The following is a description of a gene set: Genes containing one or more binding sites for (ZNF592) in their promoter regions (TSS -1000,+100 bp) as identified by GTRD version 20.06 ChIP-seq harmonization. Human Gene Set: ZNF592_TARGET_GENES from publication Yevshin I, Sharipov R, Kolmykov S, Kondrakhin Y, Kolpakov F (PMID 30445619) studied in species Homo sapiens, and this is the list of marker genes: CCDC144A, PTP4A2, MRPL22, COPS6, LNMICC, SSC4D, LARP1, E2F5-DT, COL6A4P1, BCL7C, LAMTOR1, OPN3, DBP, PDIA5, COASY, BRME1, WRAP53, EPHX2, ZFX-AS1, TMEM131L, GOLGA5, CDIP1, LEMD3, TMEM144, DHRS13, TMEM165 (transmembrane protein 165), ZNF609, PMM2, ADD2, DFFA, MGAT1, SPINT2, LTO1, NEK11, JADE1, PER3, ABHD14A-ACY1, PHF20, HDGF (NCBI Gene Id 92300), NADK, CASC3, HMGXB3, TRGV6, UQCC1, KIF2A, MACROH2A1, ZSCAN31, LINC02901 (long intergenic non-protein coding RNA 2901), CLTB, GPR107, MLPH, WARS2, WDR89, ABCC5-AS1, PSMB6, TRIM8 (tripartite motif containing 8), TLE3, UQCRH, NELFE, FABP5P3, ABCC3, ENSG00000265055, AGPAT3, LHPP, JOSD1, SUCLA2, HMCES, LINC00674, SRXN1, SNHG4, PRR3P1 (NCBI Gene Id 101060648), PKN1 (protein kinase N1), WASF2, SPDYC, TXNRD1, PABPC4, ADCK2, PRAF2, MGA (NCBI Gene Id 84130), AHCYL2, EML3, SMIM10, MRPS21, MEX3C, TRIM8-DT, SLC2A1-DT, THUMPD3, MIR4659B, STARD9, CRYBG2, ATG13, RNU5B-1, SP2-AS1, CHML, C2orf49, IRX2, MYBBP1A, MCRS1, MAPRE1, TNFRSF10C, IL10RA, PRKAR1B, ODC1, RNF166, TSSK3, LEPROTL1, EZR, TRG-AS1, CLDN4, RPSAP31, ZDHHC8BP (NCBI Gene Id 150244), RAD9B, IMMP2L, FZD6, NKX3-2, HIPK2, CYB561D2, EVA1C, SMARCD2, CDK20, KANSL3, HMGA1, ZNF566-AS1, RNF149, RAMAC, RNU5F-1, POLR3E, SCMH1-DT, PFKFB3, NOTUM, MIR451B, RRP1B, SCAPER, CALCOCO1, ZNF341, FAM78A, FBXL19-AS1, DGCR8, TRNAU1AP, RNVU1-32, CHP1, AMOTL2, PDS5A (PDS5 cohesin associated factor A), HOXB3 (homeobox B3), TEX22, SHLD3, PUF60, LINC02863, RC3H2, C2CD2, ATP2B1, SNX27, TTC13, ATP5MC1P3, ZNF385A (zinc finger protein 385A), OPLAH, USP10, POLR3A, XYLB, INSR, NUMBL, HNRNPL, RAB7A, ERP44, CARINH, CAV1, RBM8A, CHST1, NUMA1, AKR1A1, ASB8, AMN1, ARHGEF10, MAJIN, RNVU1-2A, PVT1, HES1, ARFGEF2, POM121C, MIR3939, CAST, TNFRSF1B, STAR (NCBI Gene Id 6770), FAM98B, TCTN1, LRFN4, HCFC1, UBE2F, METTL13, KLF10, MRPL20, IGF1R, NAGLU, ISLR2, CISD3, ZNF644, SMPD3, DCTPP1, IGDCC4, MELTF-AS1, GAS8, LINC03108, CHD2, PSME2P3, CILP2, NDC1, LINC01610, PUDPP2, R3HDM2-DT, AP1G1, MDH1, SUPV3L1, NUFIP2, TBXAS1, SH2D6, SLC7A6OS, ENGASE, LIX1L-AS1, RNU7-27P, HMOX2, METTL23, IDH3B-DT, DEK, COL4A2, BCL7B, RPS6KA3, LINC01623, GFY, PROCA1, CCDC136, DDX19B, MECR, MPDU1, MID1IP1, CTSH, MFSD3, VTRNA1-3, RGCC, ELOVL1 (NCBI Gene Id 96722), TRMO, MRPL52 (NCBI Gene Id 122704), IL5, WT1-AS, GCLM, REX1BD, MXD1, FLNB, SEMA3B, HLTF, COQ8A, ACTR3C, ANO10, TTLL4, ANXA11, AVPI1, TRIM7-AS2, SMIM12, APMAP, NDUFA10, ST3GAL5, NR6A1, MITF, RNF130, YBX1, CAP1, SPHK1, MPHOSPH6, CBX7, CHMP4B, ARL16, MOB3A, FADS1, PRELID3A, CARD8, ZNF48, MSL3, MADD, CRAT, REV1, DMAC2L, YPEL3-DT, FEM1A (fem-1 homolog A), PYCR2, ADI1, IP6K1, UPF1, TOLLIP, MED16, PEMT, MRPS6, ENSG00000239137, GFUS, UGGT1, SNAI1, TMEM241, GRK6, WTAP, HJV, FHL2, UCKL1, ZNF282, SEC24C, SNF8, BAG6, KLHL21, ANGPTL6, ZCCHC7 (zinc finger CCHC-type containing 7), ZFYVE28, MFSD4B, GPR176-DT, TSNAXIP1, SYF2, RHBDD1, ATP5F1A, ALKBH2, KNL1, LETMD1, PEDS1, ZNF8-ERVK3-1, DDX50, CCS, KLF13, PSMB4, ZFP91-CNTF, NDUFAF5, SLC25A6, VSIG10L-AS1, ROM1, ACCS, EPDR1, KCNH1-IT1, PACSIN3, MYO1D, DENND6B, TRMT12, RNPC3, GLS2, RABGGTA, RAB29, HM13-IT1, MAPK6-DT, DLGAP4-AS1, SPAG4, DIAPH1, ENSG00000212144, DHRSX, PPP4R1, PTP4A1 (NCBI Gene Id 7803), LINC01732, PPP1R3D, TELO2, ARF4, BAGE2, CSTF3-DT, PUM1, MAP1LC3B (NCBI Gene Id 81631), TMC8, BEND6, TYSND1, PITX1-AS1, SLC7A5P2, WIZ, CLPX, C12orf76, CHCHD10, CCDC59, MEPCE, TCP10L2, GMEB1, APOO, ZMAT1, POLE2, LIMD1, RHBDD3, PTRH2, STK17A, OLMALINC, SBF2-AS1, RPL10, STAU2, IWS1, RNU2-2P, CDCA4, USP49, ELOVL2-AS1, ENSG00000260830, TADA2A, RP9P, GPCPD1, TFEB, DNAJC11, RFX2, CTSF, CCDC8, TXLNA, TOMM20, SNAPC4, DYNLT4, DPP3-DT, PRPF40B, HISLA, CTTN, ABHD14B, RASGRF1, GNG4, LDHA, KRT7, OXA1L, STC2, HDHD5-AS1, DNAAF5, TAF2, BTRC, DSCR9, POLR2I, C1orf159, ZNRF2, GAB2, KRIT1, STN1, CCDC106, ST3GAL5-AS1, FBXL5, SCARB2 (NCBI Gene Id 950, scavenger receptor class B member 2), ITGA3, CHD7, NCOA6, RRP1, GIT1 (NCBI Gene Id 28964), C19orf38, TMEM186, VPS36, VPS29, SPG11, GNPTAB, MIR4727, SETD2, PHACTR1, NMT1, RYK, TONSL, FOXRED2, CTDSP1, EMD, C2orf42, SRRM2, VPS9D1, CPSF1, KCNAB1, NCOA5, SRGAP2, PROCR, ENSG00000279561, CENATAC, NFIB, FABP5, TEX19, R3HCC1, DST, CXCL3, NPL, LINC01770, CYP2R1, ADAR, FNIP2, HIKESHI, BFAR, GLOD5, LACTB2, LINC02709, ZMIZ2, TTC41P, EXO5, ZKSCAN2, KHNYN (NCBI Gene Id 23351), DPP9, PLPBP, AAAS, TOB1, PRDX3, ULK3, CAB39, RAB8A, ARF6, ZNF280C, GOPC (NCBI Gene Id 57120), TULP3, CDC16, SFT2D3, DOK7, NEPRO, SMG1P3, TMCO3 (transmembrane and coiled-coil domains 3), MAP7, TRAPPC8, SNHG20, SETDB2, ATIC, ACTR3-AS1, GABPA, SORBS1, TMC6, SUSD3, MTHFD1, SLC38A1, WDR26, GGA2, ENDOD1, TMEM40, EBLN3P, PICK1, ASTE1, TNFRSF8, TRIM33, ACSL3, HS1BP3, RPS26, LHX6, FADS2, TOB1-AS1, SMC3, ARL4A, TK2, SEC61A2, PLEKHJ1, CCDC122, SLCO4A1, ZNF598, HNRNPH1, HLF, MARVELD1, TMEM14B, TRIM59, UTP14A, TPRA1, ZNF250, PDE12, EBNA1BP2, PRKAB2, PPP1CA, PCNX4, STXBP5-AS1, JPT2, NEK3 (NIMA related kinase 3), SLC12A2, TEX14, TMED1, PEAK1, STAU1, PARK7, CAND1, RPS11, PUM2, OPA1, TMEM11-DT, PIGL, TIMM50, PDCD6IPP2, NOC4L, TUBB2A, MCCC2 (NCBI Gene Id 64087), HFE, BCL9L, PARVB, ACER3, PAXIP1, SLC9A3-OT1, CSNK1G1, KATNA1, LARP1B, ZNF497-AS1, SKAP1, PTCD1, PEX14, EOLA2, SUDS3, KDM3B, NXT1 (nuclear transport factor 2 like export factor 1), GPR176, NDST2, ATP5F1B, FARSA, OXA1L-DT, DGAT2, PHF19, SNORD49B, FBXO34-AS1, HTATIP2, VPS37D, EIF3B, TGIF2, NOS3, RNU6-1, ATMIN, PRANCR, WWP2, CCDC88B, BPTF (bromodomain PHD finger transcription factor), CSRP1-AS1, TMEM183A, GNAS, RIOX2, ACSF3, EIF2B5, RNF213, C2orf92, ZNF580, CNOT6, ADSS2, ZNF707 (zinc finger protein 707), LIG1, FAM157A, REXO1, FAM24B, ENSG00000255326, VCPIP1, VDAC2, TMEM201, GPR180, LINC03072, TNXA, TULP2, CARM1, ICAM1, PPT1, SLC25A45, BUB1B, CNOT9, HACD3, SAXO5, SETD4, GCFC2, EBAG9, ZFYVE1 (zinc finger FYVE-type containing 1), ACBD5, ARHGAP22, RAD9A, LDLRAD4, TGFBR3, ARHGAP25, NARF, PHLPP2 (NCBI Gene Id 23035), DEF8, SMARCC2, CCDC137 (coiled-coil domain containing 137), GPR3, LINC01932, RENBP, FRMD8, PXN (paxillin), ZFPM2, FAM76A, TCERG1, DNAAF4, RNU6-194P, MTMR10, PROKR1, ADNP, BCKDK, SAMSN1-AS1, GCN1, EGFLAM-AS4, FBXO31, PRKAR1B-AS1, ITGAE, SEC24B, ALG5, EEIG2, LINC01089, NAPSA, THEM6, AKAP10, PPP4R1-AS1, SMURF2, PYGM, YPEL3, MTMR9LP, F11-AS1, SLC35F6, PDE4A, BTBD19, FOXK1, LRRC56, SPTSSB, PCBP1-AS1, HMGN1P37, ZSWIM9, LINC02985, XPO7, CYTH3, CATSPERG, PLEKHG2, RNA5SP236, KLF6, RPTOR, HMGB1, IFRD2, UBE2V2, ODR4, MATR3, ELOVL2, SEH1L (SEH1 like nucleoporin), MYO3B-AS1, EPM2A-DT, NBPF11, CTCFL, METTL2B, NYAP1, GCLC, DNAJC12, KHSRP, LINC02159 (long intergenic non-protein coding RNA 2159), LTBR, SP1, SYNGR3 (NCBI Gene Id 9143), C15orf61, ALDH3B1, HMMR, NFIA-AS1, DEGS1, VPS26C, CDRT15P3, RFFL, ANP32B, PBX3, DPP3, GREB1, ZNF248, SCAND3, ZNF408, IMPDH2 (NCBI Gene Id 3615), RPL37, MIR4530, PDS5B, TH2LCRR, PLEKHG4, RANBP2, CLCN7, FAM138E, SLC6A6, NUP98, SDF4, TDP2, ERI1, LNX1, MELTF, TARS1, RAE1, VPS26B, FKBP5, VPS16, HMX3, ANKRD13A, IFTAP, KIFC1, VTI1B, ERP29, SNORD25, CFB, HELZ, SCML2, DCAKD, ESYT2, RAD51C, LINC01702, MIR4470, XKR9, DNAH10, ZNF747, ENSG00000263280, ZNF77, HOXB-AS3, SUMO2, TMEM258, FAM50A, G6PD, B3GAT3, SYT12, B9D2, HSPG2, NAPEPLD, HEIH, EIF3L, TRMT10B, N6AMT1, DLGAP4, TMEM184A, FBXO34, SFT2D2, CISD2, OSBPL8, MGME1, PSMC5, MIS18BP1, VILL, MCRIP2, PAXIP1-DT, MYO18A, SIAH1, CHASERR, HMBS, EOLA1, LMCD1-AS1, ASPH, YTHDF1, NFE2L3, ZNF155, HADHA, STOML1, NRF1, CCDC83, ABCA17P, F2RL2, RHOH, LINC02354, LIMD1-AS1, KMT5B, ICE1, CHID1, ZNF226, RLIM, ACSM3, ZFAND5, HM13-AS1, GTF2IRD1, ZGPAT, BRF1 (NCBI Gene Id 90137), EGLN2, CAPN7, MMP24OS, USP37, PLCB2, TMX4-AS1, RILP, HCG20, PPFIA4, POLR3G, DLG5-AS1, NADK2, AGPAT5, ABHD17B, AP2S1, EMC1, IL13RA1, PLK3, PER1, ATP7B, KSR2, LINC02777, FAM217B, MMP11, GTF3A, ATP2B4, TOM1L2, DNLZ, DDX23, ZKSCAN2-DT, WDR83, ANKRD36B, GFM1, FOXK2, WDSUB1, MDN1, NEU4, CYC1, ZNF566, RNY3, BCAP29, HARS1, PIP4K2A, HMG20A, HARS2, DNM2, RCE1, RNU6-9, TRA2B, PPAN-P2RY11, STXBP2, SPOPL-DT, ZNF581, LINC02952, POU6F1, PINK1, CAPNS1, TRAP1, SUPT16H, CFAP97, ANKRD53, USP32, ATG12, DRAP1, ZNF775, KLF11, L3HYPDH, EME1, PANK4, ANKLE2, B3GNT4, ASAP3, ETV2, WIPF2, ATP5MF-PTCD1, CLPB, NTPCR, SNHG29, DDX11L10, NSUN5, IMPA2, KLRG2, NBPF12, SUPT5H, AHCTF1, ARHGEF6, ALDOA, RDH13, MIR4706, RGS10, MMP25-AS1, PECAM1, EXD1, FICD, NUDT13, METTL5, ATP9B, LCA5L, RANBP10, MAPRE2, RSAD1, SHF, MAX, NFE2L1, KLHDC10, GNA13, CFAP418, ZNF646, PIWIL4, ARL5AP5, DUSP14, SNX5, CRK, PRKACA, PIM3, RAB6A, HNRNPA0, IL34, LINC01424, GHET1 (gastric carcinoma proliferation enhancing transcript 1), MTERF3, WT1, DNAAF4-CCPG1, UBAC1, MAPKAPK5-AS1, ENSG00000255428, HACD2, ADK, DNAJA3, SHROOM1, HNRNPU, RBM4, DNAJA2-DT, OCIAD1, MYH9, GOSR2, RNY4, CCDC85C, ST3GAL2, MEST, ZNF280D, F2RL3, CSRP1, STK19B, SLC2A4, TCEA2 (NCBI Gene Id 6919), SERPINE1 (NCBI Gene Id 5054), HCG14, P2RX2, PRECSIT (p53 regulated carcinoma associated Stat3 activating long intergenic non-protein coding transcript), LRSAM1, RAPGEF1, CEP350, ARFRP1, COCH, VTRNA1-2, INTS1, WRNIP1, PPP1R12C, PAICS, MINCR, RWDD3, LINC01629, PPP1R14B, TANGO6, MIR153-1, RWDD3-DT, EZH1, DYNC1LI2, EEA1, BOD1, WDPCP, MCRIP1, LSM14A, POLG-DT, NCAPD3, ALG1L13P, SBNO2, PUS1-AS1, TEX30, SNRNP70, ATP2A3, GRN, ZNF341-AS1, FBXO38-DT, CTSD, CHD9, SF3A2, LINC00689 (NCBI Gene Id 154822), PCNX4-DT, SH3GL1, ANKRD54, RALGDS (ral guanine nucleotide dissociation stimulator), KDM3A, TEDC1, MSL3-DT, STKLD1 (serine/threonine kinase like domain containing 1), DYM, PIEZO1, PNPT1, CIC, INVS, CERS6, RAB4A-AS1, HSP90AA1, MAPK8IP3, TRIM39, SKIDA1, EWSR1 (NCBI Gene Id 2130), IFITM2, MIRLET7IHG, GLS, GTF3C4, ZBTB8OS, TRPV2, MTHFR, ACACA, TPR, PPM1A, RNF223, TOMM34, PDF, BTNL9 (butyrophilin like 9), IFI27, UBE2G2 (ubiquitin conjugating enzyme E2 G2), MMRN2, MIR6508, WBP1L, RPL13, PTPRS, TSNARE1, NRDE2 (NRDE-2, necessary for RNA interference, domain containing), RADIL, TFAP2A, ARHGDIA, CREM, DHX40, PPP1R3F, FAAP20, DUSP28, ZNF460, PLXDC1, CCDC174, MYLK-AS1, NCOA3, FPGS, KCNN4 (NCBI Gene Id 3783), ZNF444, DIABLO, LNCATV, MFSD4B-DT, VSIG10L, C17orf99, NDUFS3, IL1R1, HMGB3P22, SRSF1, GALNT7-DT, PAFAH1B1, SRRM3, ENSG00000266401, BMP1, DIAPH1-AS1, CAPG, CXCL11, RBBP8NL, NME1 (NME/NM23 nucleoside diphosphate kinase 1), RAD54B, PXK, SEL1L, MIR5684, PKNOX1, MIDN, ABCF3, CACTIN, SACM1L, EMG1, RIOX1, CISD1, SLC4A2, SEC16B, CCDC57, STX3, SCRIB, KIAA2013, MRPL53, PTPA (protein phosphatase 2 phosphatase activator), CTBP1-DT, EIF1P2, MIR4766, RHOF, SNORD54, JKAMP, VPS4A, DHX8, ENSG00000227355, NR2F2, CNIH3, IKBKB-DT, HERC1, INF2, SYPL1, PPAT, TRAF4, UTP11, OXSR1, ESD, SNX9 (NCBI Gene Id 51429), METTL26, TRAPPC13, VMP1, STAT6, CCDC183, FBXW5, FEN1, PIR, ZNF496, TPM4, TMEM11, KRT7-AS, RIN3, MORC2, ATF7IP2, SLC7A7, CTNNBL1, SLC5A3 (NCBI Gene Id 6526), COMTD1, RPS20 (NCBI Gene Id 6224), RHOBTB1, AGPS, ADSS1, PNPLA6, VDR, ELOVL5, KAT5, SLC7A8, CARD8-AS1, CCDC125, SNHG7, KSR1, FBXO38, EXD3, COPS7A, RELT, PTMA, PUS1, RNVU1-15, TNIP2, BMP8B, DYNC1LI2-DT, UBXN11, RNF138, ZNF398, FN3K, ATP8B1-AS1, LINC01547, TRIM45, GGACT, MRTO4, EHF, DHX58, SPOPL, IDH2 (isocitrate dehydrogenase (NADP(+)) 2), MRPL43, GRK4, DDX3ILA1, R3HDM2, REEP3, ESF1, FBXL18, MVK, TCFL5, LRRC3-DT, TMEM248, DDX11L2, ZNF584, TRIM47, NORAD, TMEM80, PPP4R1L, AKAP11, LINC02695, RAB11A, UBE2F-SCLY, SYT8, MGC4859, USP14, DEPDC7 (DEP domain containing 7), TMEM44, CEP131, CFAP418-AS1, CP, PGD, SEMA3C, ANKRD52, TASOR, SLC12A2-DT, UFSP1, IDH3B, RPL36P8, ZNF32, MTREX (NCBI Gene Id 23517), PLLP, KLK12, NRARP, MIR193A, RBBP4, UCP2, CASP7, CKLF, RNH1, SLC7A5P1, OTUD4, NETO2, EIF4ENIF1, SNHG1, KIAA1958, KLHL17, RERE, NEK8, DNAJA1, FIRRE, MIER2, PPP4R2, ZFYVE27, FAM174C, NKD2, CDK5RAP3, CYB561, SIRT7, E2F6P4, ODAD3, RHOG, ZNF668, RNPC3-DT, RYBP, UBTD1, POLR1A, EML4, WDR74, KMT2C (NCBI Gene Id 80260), MALAT1, LINC02252, IKZF3, IRF2BP2, MAP2K2, WEE1, APPL2, NGLY1, L2HGDH, CBLN3, ZMYND8, MIR4492, CFLAR-AS1, TMEM187, DEDD, CNOT2, CENPN-AS1, SEPHS2, LSM10, GTF3C3, GATAD2A, ING4, DHDDS, NOC3L, HMBOX1, MAZ, AGO3, CACNA2D4, RPS13, TSSC4, DNAJA2, KRR1, CASTOR2, SMAD2, EVI5, HNRNPF, AFF4, RPL12, CST9, FBXO30, ARV1, FCGR3A, GASAL1, TARBP2, EHD1 (EH domain containing 1), SLCO2B1, WARS2-AS1, TBX10, SCAMP5, CHCHD1, RN7SKP119, ZNF513, ZMYM4, SNORD26, NT5C, RBM17, DNA2, REXO2, ENSG00000206898, LINC02577, RNU6-1160P, SEPTIN9, ZFAND4, STUB1, MIR3181 (NCBI Gene Id 100422972), EIF2D, ZSCAN5A-AS1, CAPZA2, ARRDC4, DUS1L, GNL3L, RCC2, PPFIA3, CYLD, ARHGAP1, RBM26, NR0B2, N4BP2, ZNF248-AS1, SDHC, WDR76 (WD repeat domain 76), SRGAP3, NECTIN2, CALM2, RRP36, MEIOB, RNU1-108P, SYT17, TBCD, CDK5, TNFAIP8L1 (NCBI Gene Id 126282), C5AR2 (NCBI Gene Id 55868), ARHGEF5, KCTD5, POLD1, ZFP91, GIRGL, STK25, LZTR1, TUBGCP3, ATG16L2, VPS13D, HCG18, UBTF, MAP4K4, H4C3, DNMT3B, UBA5 (NCBI Gene Id 79876), BAIAP2L1, CERNA3 (NCBI Gene Id 105375847), DNALI1, KIAA0232, TRIB3, FNBP4, PITX1, CSTF3, DERL2, RHOT2, CANT1, ASPSCR1, SAMD9L, CIRBP, PLSCR1, SART3, PDHB, SGPL1, PGBD2, ZNF746, SRSF4, AEBP2 (AE binding protein 2), ODC1-DT (ODC1 divergent transcript), TSPAN14, SMPD2, DPP7, H2AZ2P1, DGUOK, ZMYND15, RNF38, CCAR1, METTL25, VAC14, FAM234A, ELOVL3, USP11, MC1R, LINC00963, HSDL2-AS1, ATP5PF, DEF6, AP3S1, TSPO, VARS1, ADRM1, CTBP1, ZNF510, SLC26A4, ATP2A2, CPNE2, RHCE, SBNO1, PRDM15, CCND1, WNT10A, VWA1, MFAP3L, RPL36AP19, LINC01641, PCBP4, CNTD1, RNU6-1219P (NCBI Gene Id 106480649), COA3, INTS9, MACC1, MIR5696 (microRNA 5696), RASIP1, TRIM59-IFT80, ZNF131, TOMM40, MIR6070, DLG5 (discs large MAGUK scaffold protein 5), RNY1, SLC43A3, PRKCQ-AS1, TNFRSF10A-DT, CCDC88C, LSM11, VPS37B, IBA57-DT, IRX3, TMEM268, PRCC, SRGAP1, SNORD68, KIF9-AS1, SLC34A1, TCF25, PRMT7, PPFIA1, DOCK1, ATP5MF, STRIP1, SSBP4 (single stranded DNA binding protein 4), FAM32A, TP53, FTSJ3, PHF8, FBXL19, UBXN8, LINC03016, CXCL16, UPF2, NANP, PEDS1-UBE2V1, SRP19, MIA2, SGTA, TMED3, LTBP4 (latent transforming growth factor beta binding protein 4), SLX9, KBTBD6, NIBAN2, RSRC2, RPL7P41, TRIP6, NSD3, DR1, KCNH1, SKA1 (NCBI Gene Id 220134), DEAF1, SLC29A1, ATP5MC2, GYPA, C10orf95-AS1, RIOK2, IBA57, RSRP1, GPR160, SH3TC1, IL4I1, HADHB, CEP68, KLHL20, TKT, ITGB4, CCDC120, CDH1 (NCBI Gene Id 999), GSTP1, NME6, MCL1, PCNX1, IFI16, HEXIM1, VCF1, C6orf62, DLD, CDK5RAP2, ACADM, RMI2, ZNF384, S100Z, LAMB3, SERPINB6, PNMT, FANCL, SYCP2, PMS2, CUL4B, ENSG00000233017 (NCBI Gene Id 105372710), MIR4526, PCCB, PSD4, SLC7A5, NDUFA13, CFAP99, NUDCD2, ABCA3 (NCBI Gene Id 21), KLC1, CCDC6, C10orf88, IQCH-AS1, WDR83OS (WD repeat domain 83 opposite strand), LACC1, CKLF-CMTM1, PPM1L, PPAN, TMEM116 (NCBI Gene Id 92920), SRSF5, ANTKMT, LRRC8D, MIR4736 (NCBI Gene Id 100616220), CFLAR, LUC7L, CENPA, CTU2, SLC3A2, NFIA, NAA80, TBC1D31, MALSU1, PLXND1, FXYD5, SNX25, ICAM2, ORAI1, SCARB1, ZC3H7A, TEAD3, ATF5, LGALS8, CHCHD2P2, PBX3-DT, PCBD2, GTF2F2, SSR3, H3-3B, PCAT14, UCP3, SLC19A1, BICD2, NOP14, ZNF276, LINC02934, VMA21, LASP1, SURF6, ZNRF1, RAB3IL1, POLE4, POGK, TTC39A, OXSM, IL6, C11orf58, DHX29, NUP62, SYT5, PDE3B (phosphodiesterase 3B), KCTD10, BAALC-AS1, CELF1, AGL, FAM174B, ITFG1-AS1, ZNF12, TCAM1P, ZFX (NCBI Gene Id 7543), CMTM3, PTDSS2, TMBIM1, HMGN1, LEMD2, MIR3188, SURF4, E2F6, KLHL6 (kelch like family member 6), ZNF815P, LINC02916, NAGA, RBM28, PRDM4, C11orf68, BACH1, GALNS, NUTM2A-AS1, LRRFIP1P1, IDH2-DT, GDI2, GPSM3, PHB2, CDKL3, KCTD21-AS1, SEPTIN5, POMT2, ACBD4, RNF4, LINC00607, EOGT, TRPC4AP, C17orf58, RPL31, NAGK, LRRC61, GOLGA8A, PC, UQCRQ, ZNF8, MEF2D, TRIM23, HSPA9, PRICKLE3, FBXW11, CIAO3, NPRL2, TACC1, FAM171A2, ZNF76 (NCBI Gene Id 7629), SREBF1, TASOR2, GAPDHP16 (glyceraldehyde-3-phosphate dehydrogenase pseudogene 16), REPIN1, LINC01002, MAPT, MAK16, ECE1, CSNK1D, ENSG00000223598, TP73-AS3, SRRT, CPEB4, SMC1B, ING5, SEC14L1, AZIN1, SOX6, MAPK3, CLDN12, USF2, CDCA3, ARHGAP45, EOLA1-DT (EOLA1 divergent transcript), ANKRD28, SLC9A3-AS1, MTNAP1, TBX6, PPA1, FBXW4, MIR4789, EIF2AK1, TXNIP (thioredoxin interacting protein), HDAC2-AS2, TCP10L, PTDSS1, CHMP3, ITGAM, CD22, NUP210, MIS12, KNTC1, LILRP1, PRDX3P2, TTLL12, NARF-AS2, RNF139-DT, CDKN2C, SLC2A9, GSN (NCBI Gene Id 2934), PLEKHA1, C4orf3, SMIM5, MLXIP, SLC39A13, DNPH1, ZGLP1 (NCBI Gene Id 100125288), JMJD6, ZNF331, SLC39A14, NSD1, FAM124B, INTS4, LINC01976, ECHDC3, HSF2BP, SEC1P, STX1A, LAGE3, C9orf85, PRSS8, CPQ, BIRC5, TWNK, HDAC2, S100A2, STEAP1B, TMEM161B, UBE2V1, MAPK1, RORC, MARCHF10, FER1L4, HOMER2, ROCK1P1, LRP3, MAPK8, UBE2D2, RNU6-1055P, FAM222A, LUC7L3, NME1-NME2, ALOXE3, EEF2K, BCAS3, C2, KBTBD6-DT, SZRD1, NOSIP, POLG, MPDU1-AS1, DGKZ, ADAP1, LPXN, DDX51, UBE2D3, RHNO1, CRAMP1, DENND1A, HOXB6, ZSCAN5A, LGALS8-AS1, PHF5AP7, CD59, ABCA5, STK40, CCDC18-AS1, POLR1B, HYAL3, C5orf15, REN, COL9A2, PREX1, FAM53A, TBC1D7, C7orf50, RAB4A, SDHCP3, ZNF7, C1orf198, FCSK, EXOC7, ASCC2, ANKIB1, BUB3, CAB39L, ALCAM, LRP5, NOM1, PTHLH, FBXO42, PTCD3, TMEM63B, EOLA2-DT, POU2F2, DEUP1, RPS27, RIBC2, PIH1D1, NCOA4, ARFGAP3 (NCBI Gene Id 26286), GGT1, ENSG00000235978, ABCC5, CWC25, ALDH5A1, PCIF1, ANKRD50, PGGHG, SH2B2, ANKRD65, CTHRC1, ARF1, AIMP2, PPIH, GAREM2, TBCK, NOXA1, EXO5-DT, ENSG00000242611, RFC1, CAPRIN1, CARMIL2, NSFL1C, SIDT2, SDC3, LRRC41, SH3BGR, TSSK6, SLC17A5, SAYSD1, OSCP1, RHPN2, WNT2B, LMCD1, HDHD5, MAPKAPK5, KCNC3, SNORA74B, GOSR2-DT, CYTOR, GLG1 (NCBI Gene Id 2734), EEF1DP1, TPBGL-AS1 (TPBGL antisense RNA 1), CCDC144BP, WHRN, HRAS, PPP6R3, MAG, BCAT1, FAM133B, BTAF1, PRKCQ, MAPK6, PTPMT1, RAD50, MGLL, WSB1, USP22, CEBPB-AS1, UROS, RNVU1-27, TBCB, INPP4A, RPH3AL, SHLD1, RNF145, PARP12, WDR36, C10orf88B, SNX18, LDC1P, BDP1, MRPL33, EIF5A2, CERS4, PRKCSH, LRRC37A3, SLC2A1, PLSCR3, ZBTB38, ZNF628, RHEB, HILPDA, AGAP4, ARMC7, FOXD1, HLCS, PPP2R2D, HILPDA-AS1, PPEF1, NUDT4, SLC9A5, FSCN1, ALDH1A2, NMRAL1, UBE2G1, JUND, CC2D1A, BCAS4, CHST10, MRPL27, RHOBTB3, EED, SLC44A1, LIN7B, C8G, LINC01962, PNPO, THSD4, DDX55, SLC25A10, DNM1P35